Given this list of marker genes FAT3, AHI1, SAMD11, BCL2, ANKRD24, TH, BAK1, NECTIN1, FGFR2, CHD7, GRXCR1, MFAP5, ARL6, TTC8, GNAT1, TENM3, SIX3, HIPK2, FRZB (NCBI Gene Id 2487), CRB2, HIF1A, RARB, FGF9, SIX2, IFT122, SDK1, CALB1, SDK2, NECTIN3, MAPK1, TSPAN12, USH1C, CYP26B1 (NCBI Gene Id 56603), ABI2, SKI, FOXI1, LRP5 (LDL receptor related protein 5), DZANK1, RHO, RARG, TWIST1, OTX1, NKX3-2, NDP, FRS2, SOX8, STAT3, WNT1 (Wnt family member 1), TIFAB, MYO7A (myosin VIIA), HMX3, STAU2, AGTPBP1, ZHX2, FZD5, TTC39C, KCNQ4, NRL, NTRK2 (neurotrophic receptor tyrosine kinase 2), MYO6, MFSD2A, EYA1, JAG1, USH1G, PITX3, DVL2, MSX1, FJX1, FOXG1, NOG, GATA3, MEIS1, SOD1, LARGE1, WNT2B, RAB37, CTHRC1, GNAT2, WDR19, YY1, MAFB, SLC44A4, GBX2, ROM1, OLFM3, MYO3B, HIPK1, HESX1, SIX1, POC5, BMP7, FOXE3, WNT9A, MAN2A1, CTNNB1, TMEM215, SP3, MFAP2, PAX8, RPGRIP1L, WNT16 (Wnt family member 16), GNGT1, PDE6C, TBX2, NOTCH2, RBP4, DSCAM, WDPCP (WD repeat containing planar cell polarity effector), EPHA2, KDM2B, ZIC3, COL8A1, NEUROG1, CITED2, PAX6, DLX5, LHX1, WNT3A (Wnt family member 3A), LRIG3, FSCN2, SOX1, ALDH1A3, PTK7, VSX2, IFT172, SOX12, CDH23, VEGFA, TMIE, MEGF11, TBC1D20, RPGRIP1, SPRY2, MFRP (membrane frizzled-related protein), IMPG2, FOXN4, WNT5A, RORB, MYC, NOTCH1, INSIG1, SLITRK6, HDAC1, TBX3, KDR, BBS10, NAGLU, ADAMTS9, RDH13, LCTL, MYO3A, EDN1, NTN1, MFN2 (mitofusin 2), FAT1, SPARC, CEP290, HCN1, CDON, SOBP, PLS1, NIPBL, BBS4, TSHZ1, COL8A2, PPP2R3A, RPL38, RS1, NHERF1, PRKCI, FGFR1, FZD2, PROM1, BAX, WNT2, RAC1, HPN, VANGL2, THRB, EDNRA, ZIC1, AQP5 (aquaporin 5), C12orf57, HOXA1, PTF1A, MAPK3, PAX2, DCANP1 (dendritic cell associated nuclear protein 1), COL11A1, MYO15A, TECTA, PDZD7, GRXCR2, POU4F3, DLL1, GLI3, STRC, CABP4, OSR2, CHRNA9, FASLG, FOXL2, SOX4, BLOC1S5, FZD3, ATP8A2, PITX2, THY1, REST, VSX1, EPHB1, DVL1, CRB1, COL5A2, NR4A3, HMGN1, FBN1, RPGR, SIX4, COL2A1, NF1, PHACTR4, SLC1A1, FZD6, BCAR3, RP1, IHH, COL5A1, TPRN (taperin), SOX11, HOXC13, SCRIB, FGF8, CRYAA, SHROOM2, CNTF, TBX1, TBX18, CLRN1, CLRN2, FGF2, TFAP2B, PRDM1, CHRNA10, FGF10, EFEMP1, TRIOBP, INTU, PRKRA, GJB6, OSR1, STOX1, FBN2, PROX1, DLX6, TULP1, ATF4, ZEB1, LHFPL5, GRHL3, LRIG1, CRYGB, BMP4, WHRN, BCR, PTPRM (NCBI Gene Id 5797), ATP6V1B1, RING1, TCAP, ATOH1, EPHB2, TSKU, KCNQ1, GSC, HOXA2, STRA6, SEC24B, OTOP1, INSIG2, TDRD7, PRRX1, HDAC2, VAX2, FOXF2, TFAP2A, HMX2, AQP1, IRX5, GDF11, NR2E3, DIO3, GATA2, SOX9, POU3F4, NKD1, SAMD7, ITGA8, here is a description of the gene set: studied in species Homo sapiens Human Gene Set: GOBP_SENSORY_ORGAN_MORPHOGENESIS Morphogenesis of a sensory organ. A sensory organ is defined as a tissue or set of tissues that work together to receive and transmit signals from external or internal stimuli. Morphogenesis is the process in which anatomical structures are generated and organized. Organs are commonly observed as visibly distinct structures, but may also exist as loosely associated clusters of cells that work together to perform a specific function or functions.